Given this list of marker genes EP300, FAM220BP, PTPRT, HSF1, PTPN2, FAM220A, DTX3L, H2BC9, CEBPA (NCBI Gene Id 1050), SPI1, PPARG, PARP9, here is a description of the gene set: species: Homo sapiens Human Gene Set: GOMF_STAT_FAMILY_PROTEIN_BINDING Binding to a member of the signal transducers and activators of transcription (STAT) protein family. STATs are, as the name indicates, both signal transducers and transcription factors. STATs are activated by cytokines and some growth factors and thus control important biological processes including cell growth, cell differentiation, apoptosis and immune responses.